The following is a description of a gene set: Any process that activates or increases the frequency, rate or extent of myeloid cell differentiation. Human Gene Set: GOBP_POSITIVE_REGULATION_OF_MYELOID_CELL_DIFFERENTIATION studied in species Homo sapiens, and this is the list of marker genes: OCSTAMP, MIR145, IL20, PITHD1, FAM210B, MED1, KLF10, MTURN, SMAP1, POU4F1, KITLG, MAPK14, NCKAP1L, RUNX1, HMGB1, MIR222, SCIN (scinderin), IFNG (interferon gamma), POU4F2, FAXDC2, GATA1, STAT5B, SLC9B2, FOXO3, CD101, LIF, IL12B (NCBI Gene Id 7907), RCOR1, IL23A, HSPA1B, HSPA1A, STAT1, ISG15, HLA-DRB1, PF4, PRMT1, TAL1, TNF, TYROBP, CSF1 (colony stimulating factor 1), HCLS1, NEDD9, CTNNBIP1, EVI2B, HAX1, TMEM64, RIPK1, RAB7B, ID2, ABCB10, PPARGC1B, STAT3, PLA2G3, TNFSF11, TNFRSF11A, NOTCH2, CCR1, HSF1, DCSTAMP, CASP8, HMGB2, ACVR2A, RPTOR, CD74, GLUL, IL23R, CREB1, ANKRD54, TRIB1 (NCBI Gene Id 80272), CALCA, IL5, PPP3CA, EEIG1, STAT5A, KAT7, PRKCA, MIR221, TESC, CD4, MAPK11, RB1, JAG1, MPL, MIR486-1, ZFP36L1, FADD, THPO, CSF3, TM4SF19, HOXA5, ZNF16, TREM2, FES, TRAF6, ARNT, ETS1, GPR68, GATA2, ACIN1, INHBA, ACVR1B, HIF1A, LEF1, IL17A, PRKDC (protein kinase, DNA-activated, catalytic subunit), FOS, TGFB1, RHEX, BRD1, INPP5D, IL34